The following is a description of a gene set: Human Gene Set: GOBP_LONG_CHAIN_FATTY_ACYL_COA_BIOSYNTHETIC_PROCESS species: Homo sapiens The chemical reactions and pathways resulting in the formation of a long-chain fatty-acyl-CoA any derivative of coenzyme A in which the sulfhydryl group is in a thioester linkage with a long-chain fatty-acyl group. A long-chain fatty acid has an aliphatic tail containing 13 to 22 carbons., and this is the list of marker genes: ELOVL6, ELOVL3, ACSL3, ELOVL7, ACSL5, ELOVL4, TECR, ACSL1, ACSBG2, HACD1, HSD17B12, ELOVL1, ELOVL2, ACSBG1, ACSL4, ACSF3, ACSL6, ELOVL5, HACD2